The following is a description of a gene set: In innate immune responses, activation of Toll-like receptors (TLRs) triggers direct antimicrobial activity against intracellular bacteria, which in murine, but not human, monocytes and macrophages is mediated principally by nitric oxide. We report here that TLR activation of human macrophages up-regulated expression of the vitamin D receptor and the vitamin D-1-hydroxylase genes, leading to induction of the antimicrobial peptide cathelicidin and killing of intracellular Mycobacterium tuberculosis. We also observed that sera from African-American individuals, known to have increased susceptibility to tuberculosis, had low 25-hydroxyvitamin D and were inefficient in supporting cathelicidin messenger RNA induction. These data support a link between TLRs and vitamin D-mediated innate immunity and suggest that differences in ability of human populations to produce vitamin D may contribute to susceptibility to microbial infection. Human Gene Set: GSE8921_UNSTIM_VS_TLR1_2_STIM_MONOCYTE_24H_UP Genes up-regulated in monocytes (24h): untreated versus M. tuberculosis 19 kDa lipopeptide. from publication Liu PT, Stenger S, Li H, Wenzel L, Tan BH, Krutzik SR, Ochoa MT, Schauber J, Wu K, Meinken C, Kamen DL, Wagner M, Bals R, Steinmeyer A, Zügel U, Gallo RL, Eisenberg D, Hewison M, Hollis BW, Adams JS, Bloom BR, Modlin RL (PMID 16497887) species: Homo sapiens, and this is the list of marker genes: IL5RA (NCBI Gene Id 3568), IVD, FCRL1, PWWP2A, PPFIBP2, RAB19, DGUOK, PPARG, C3orf33, CDC14B, SLC22A23, GTF2H2 (NCBI Gene Id 2966), ETNK1, RYR3, UBQLN1, EBF1, RAMP1, DAPP1, C1QA, POGK, RPL18, RALGPS2 (Ral GEF with PH domain and SH3 binding motif 2), RAP1GDS1, FBXL4, AGRN, HCK, TXLNG, ITGAL, HNRNPH3, RGS1, STAB2, ENSG00000267882, SUGP2, ATP10D, CD79A, IKZF2, FBRSL1, IL15, MARF1, IRGM, FUT4, MAP3K5, MRPL16, PIK3AP1, ISG20, ELP3, LRP6, KLRC1, CRIM1, SRSF5, AKT3, MAPK8, IGHM, IL1B, EEF2K, GIMAP1, TBC1D9, RELB, TAGAP, MIA2, CTNND2, RBAK, CSAD, IGKC, C1orf53, FAM13B, B2M, ZNF619, EVL, TSLP (NCBI Gene Id 85480), DCP2, FCRLA, RMND1, FOXP1, RAB30, CD28, USP10, GIMAP8, IRF9, MEIS1, TMCC3, NBR1, RNF114, CRLF3, ERMP1, TRIM7, RASA3 (NCBI Gene Id 22821), LPIN1, CALCRL, FYB1, TMEM65, PTPRC, MEF2A, NATD1, ISG15, PGLYRP2, KAT6A, TSPAN33, PLA2G2D, EPB41L3, CCNT2, GPM6B, TGIF1, YTHDF2, GDPD1, VAV2, FTX, LPIN2, RASGRP3, AVPI1, PLPP1 (phospholipid phosphatase 1), ARPC5L, SBK1, CCR6, KYNU, PSME2, UNC13B, CCR9, PPP1R12B, TUBB2B, SKIC3 (SKI3 subunit of superkiller complex), ST6GALNAC2, ADGRG6, EEF1A2 (eukaryotic translation elongation factor 1 alpha 2), SCPEP1, HMG20A, BLVRB, LETM2, CTSW, CD163, RABEP2, MCCC1, PAK1, SELENOM, DTX3L, ADAM22, FKBP9, UBE2E2, CR2, GTF2IRD1 (NCBI Gene Id 9569), PRPS2, FYCO1, IGF1 (NCBI Gene Id 3479), EVI2B, ERMARD, CEP70, COL14A1, POGLUT3, SFT2D1, PROCR, CDC42EP2, POM121, DHX57, SCD, WIPF1, SPIRE1, PRXL2B, GNAQ, CFAP141, RBBP7, ACER3, HPGDS, RPL17 (NCBI Gene Id 6139), MCCC2, KCTD6, PPP1R14A, CCR7, TCEA1, AQP9, CREG1, B3GALNT1, VSTM4, USP18, CCDC12, CD7, FRMD4B, RAPGEF1, PARP6, GBP2, CD86, ST8SIA1, NAT8L, CCDC107, ICAM2, POU6F1 (POU class 6 homeobox 1), CD83, DIPK2A, PTGIS, MYCL, FGD3, CAMK1, DOK1, USP11, CXCR5, C1QB, RUVBL1, ETV5, HLCS, PATJ